Given this list of marker genes H2BC9, PIK3C2A, ZNF516, PLCB1, SLCO3A1, CLK1, PYY2, IFITM2, UBXN2B, FLT3, TMEM140, CTNNBL1, CYBB, LRP12, BSN, RHEB, PDE6G, ZNF750, ST3GAL6, CDK19, PPP2R5A, GIT2, HBB, PTGS1, PEX1, USP8, ANXA1, CD63, MYL12B, FCGBP, KATNBL1, CA3, NCF4, ARHGEF10, DYNLT1, TSC22D3, CTCF, ILRUN, HLA-DPA1, GARNL3, SLC10A3, LYL1, OSGIN2, PAPOLG, C11orf71, AKAP17A, WASHC4, IGLV1-44, EIF1, CCSER2, PTX3, PDCD6IP, MBP, SPTLC2, PSTPIP2, BST1, HTR4, FIG4, GSAP, HSPA1A, RAD51B (NCBI Gene Id 5890), TMED5, RASSF2, TIGD6, SRD5A1, OSBPL11, PECAM1, CASP4, CSAD, PARP4, ANXA2P2, NLK, ADGRE1, SORCS3, PILRA, P2RY14, PAFAH1B1, CEP63, CR2, PARP8, ADD3, MEGF9, SYNM, SUPT20H, GUSBP11, CALM1, HLA-DQB2 (NCBI Gene Id 3120), POGZ, NPR3, IK, BAZ2B (NCBI Gene Id 29994), SIRPA, RHOQ, ARHGAP15, ZBTB7C, CETN2, AKAP9, ADCY7, SLC38A4, CD33, TDRD7 (tudor domain containing 7), PTPRE, TRANK1, HLA-DPB1, R3HDM2, ARAP2, GABRA1, BCL6, PRKAB1, CHPT1, UBAP1, DNTT, PRR5L, ABHD5, STAG2, N4BP2L1, PLEKHF2, TTC38, CELSR1, UBA3, MAP2K4 (mitogen-activated protein kinase kinase 4), KIT, LAPTM4A, AFP, ZNF586, FAU, HGF, RIGI, ZNF37BP, DSE, CLIP2, CLCA4, NDRG1 (N-myc downstream regulated 1), FLNB, GALNT3, ATP10D, DRAM1, OSER1 (oxidative stress responsive serine rich 1), TDP2, ELOB, TMOD1, SLC4A3, DHRS7 (dehydrogenase/reductase 7), SEPTIN2, SVIL, ZZEF1, PHF21A (PHD finger protein 21A), RASGRP3, HP, RREB1, TRIM37, SHC3, RAB4A, WIF1, CLEC4A, EPB41L3, DCUN1D2, TESPA1, TRAPPC2, RARB, GDPD5, CILK1, AGTPBP1, EPAS1, SOCS5, TMEM87A, MGAM, ZFYVE16, N4BP2L2, PLAGL1, BMP15 (NCBI Gene Id 9210), WWP1, RPL28, CYB5R4, KDM5A, ACTB, TRIM5, B2M, BEX4, JAK1, TSC1, HCP5, ZMYND8, MAPKAPK5-AS1, CREG1, LSM14A, SOS2, CPEB3, BID, TFF2, MACF1, AP5M1, GALC, SERINC3, TPM1, ANXA2P1, NECAP1, PIAS3, RRAGA, TMEM80, here is a description of the gene set: Genes up-regulated in comparison of basophils versus Th2 cells. In the present study we used Affymetrix oligonucleotide microarrays to produce gene transcription profiles for the major leukocyte types in humans. This comprehensive dataset enabled us to not only establish which genes were expressed in each leukocyte type, but also which genes were expressed in each subset after activation. The used of a comprehensive dataset of gene profiles from all the major human leukocyte subsets enabled a novel and powerful means for identification of genes associated with single leukocyte subsets, or different immune paradigms. Human Gene Set: GSE3982_BASOPHIL_VS_TH2_UP from publication Jeffrey KL, Brummer T, Rolph MS, Liu SM, Callejas NA, Grumont RJ, Gillieron C, Mackay F, Grey S, Camps M, Rommel C, Gerondakis SD, Mackay CR (PMID 16474395) studied in species Homo sapiens